The following is a description of a gene set: Mouse Gene Set: MIR_216B_5P species: Mus musculus from publication Chen Y, Wang X (PMID 31504780) Genes predicted to be targets of miRBase v22 microRNA mmu_miR_216b_5p in miRDB v6.0 with MirTarget v4 prediction scores > 80 (high confidence targets)., and this is the list of marker genes: Pcmtd1, Nkapd1, P2rx7, Tes, Chrd, Scaf8, Dot1l, Ccnj, Lima1, Eps8, Pxn, Fam199x, Nalcn, Gpatch2, Prpf39, Snx30, Cdc14a, Ppp1r2, Uba3, Foxo4, Vps39, Ifi47, Agtpbp1, Hoxb8, 6030498E09Rik, Ipo11, Fhip1a, Dcdc2a (doublecortin domain containing 2a), Ano5, Smchd1, Plpp3, Gtf2h5, Cxxc4, Tbx2, Txlng, Raly, Pgm2l1, Fam169a, Cdkl2 (cyclin dependent kinase like 2), Wwox, Kcnt2, Kdm7a, Col19a1, Rmdn2, Apbb2, Elp4, Stk26, St3gal4, Irf2bp2, Tcte1, Zbtb2, Tyr, Lrp8, Plxna1, Son, Sgip1, Htt, Enc1, Tbl1xr1, Col8a1, Cox14, Itch, Gm7694, Arvcf, Nsg1, Npas2, Nek1, Cask (calcium/calmodulin dependent serine protein kinase), 1600012H06Rik, Ubr5, Evi2b, Igf2bp2, Dcun1d4, Pkn2